Given this list of marker genes Tifab, Plxna3, Plxna4, Isl1, Sema3f, Pou4f1, Tfap2a, Sema3a, Drgx, Nrp1, Neurog1, here is a description of the gene set: Mouse Gene Set: GOBP_TRIGEMINAL_NERVE_DEVELOPMENT studied in species Mus musculus The process whose specific outcome is the progression of the trigeminal nerve over time, from its formation to the mature structure. The trigeminal nerve is composed of three large branches. They are the ophthalmic (V1, sensory), maxillary (V2, sensory) and mandibular (V3, motor and sensory) branches. The sensory ophthalmic branch travels through the superior orbital fissure and passes through the orbit to reach the skin of the forehead and top of the head. The maxillary nerve contains sensory branches that reach the pterygopalatine fossa via the inferior orbital fissure (face, cheek and upper teeth) and pterygopalatine canal (soft and hard palate, nasal cavity and pharynx). The motor part of the mandibular branch is distributed to the muscles of mastication, the mylohyoid muscle and the anterior belly of the digastric. The mandibular nerve also innervates the tensor veli palatini and tensor tympani muscles. The sensory part of the mandibular nerve is composed of branches that carry general sensory information from the mucous membranes of the mouth and cheek, anterior two-thirds of the tongue, lower teeth, skin of the lower jaw, side of the head and scalp and meninges of the anterior and middle cranial fossae.